Given this list of marker genes Usp17le, Riok3, Tkfc, Ddx60, Ankrd17, Dhx58, C1qbp, here is a description of the gene set: Any process that modulates the frequency, rate or extent of the series of molecular signals generated as a consequence of the cytoplasmic pattern recognition receptor (PRR) MDA-5 (also known as IFIH1) binding to viral RNA. studied in species Mus musculus Mouse Gene Set: GOBP_REGULATION_OF_MDA_5_SIGNALING_PATHWAY